The following is a description of a gene set: Metaphyseal chondrodysplasia Human Gene Set: HP_METAPHYSEAL_CHONDRODYSPLASIA studied in species Homo sapiens An abnormality of skeletal development characterized by a disturbance of the metaphysis and its histological structure with relatively normal epiphyses and vertebrae., and this is the list of marker genes: ALG3, PTH1R, RMRP, FGFR3, AIFM1, COL10A1, MMP13, EFL1, DNAJC21, CWC27, GPX4, SBDS, HDAC6, SRP54 (signal recognition particle 54)